The following is a description of a gene set: Human Gene Set: MODULE_159 Translation regulation. species: Homo sapiens, and this is the list of marker genes: RAB8B, RAP1B, ARF4, GNL2, EIF5, RAB27A, EIF3H, EIF4B, ARF5, TUBB4B, EIF4A3, ZC3H11A, EEF1A1, ELOB, GNAS, RAB1A, ARL3, EEF1G, EIF3G, RALA, EIF3J, RAB31, ETF1, SLU7, SCG5, EIF3E (eukaryotic translation initiation factor 3 subunit E), SEPTIN7, EIF4H, EIF6, EEF2, NARS1, EIF2S1, TUFM, GTPBP6 (GTP binding protein 6 (putative)), RAB11A, ELOC, NOLC1, EEF1A2, RAB13, GNA12, EIF2S2, EIF4G2, RAB2A, RHOA, EEF1D, EIF4EBP1, ABCF1, RRAGA, SRP54, RIT1, DHX30, EIF3F, EIF5A, RAB10, EIF1, AARS1, EIF3D, EEF1B2, EIF3C, EIF4A1, RALB, SEPTIN2, EIF4EBP2, GEM, EIF3I, BZW1, GSPT1, KARS1, RAN, GNAI2 (NCBI Gene Id 2771), RAB5C, MX2, EIF4A2, R3HDM1, RAB14, CDC42, TUBA3C, RAB5A, TUBB3, ARFIP2, EIF2S3